The following is a description of a gene set: from publication Kim YS, Kang HS, Herbert R, Beak JY, Collins JB, Grissom SF, Jetten AM (PMID 18227149) Human Gene Set: KIM_GLIS2_TARGETS_UP To obtain insight into the physiological functions of the Krüppel-like zinc finger protein Gli-similar 2 (Glis2), mice deficient in Glis2 expression were generated. Glis2 mutant (Glis2(mut)) mice exhibit significantly shorter life spans than do littermate wild-type (WT) mice due to the development of progressive chronic kidney disease with features resembling nephronophthisis. Glis2(mut) mice develop severe renal atrophy involving increased cell death and basement membrane thickening in the proximal convoluted tubules. This development is accompanied by infiltration of lymphocytic inflammatory cells and interstitial/glomerular fibrosis. The severity of the fibrosis, inflammatory infiltrates, and glomerular and tubular changes progresses with age. Blood urea nitrogen and creatinine increase, and Glis2(mut) mice develop proteinuria and ultimately die prematurely of renal failure. A comparison of the gene expression profiles of kidneys from 25-day-old/60-day-old WT and Glis2(mut) mice by microarray analysis showed increased expressions of many genes involved in immune responses/inflammation and fibrosis/tissue remodeling in kidneys of Glis2(mut) mice, including several cytokines and adhesion and extracellular matrix proteins. Our data demonstrate that a deficiency in Glis2 expression leads to tubular atrophy and progressive fibrosis, similar to nephronophthisis, that ultimately results in renal failure. Our study indicates that Glis2 plays a critical role in the maintenance of normal kidney architecture and functions. species: Mus musculus Partial list of genes up-regulated in the kidney of GLIS2 knockout mice compared to the wild type., and this is the list of marker genes: PSMB9, ISG15, FCGR2A, SYCP1, FCER1G, CCL5, VIM, CXCL10, LAD1, CX3CL1, CCL8, ANGPTL4, TGFBR2, SPARCL1, FBN1, PDGFRL, IGFBP2, TSC22D1, OSMR, S100A6, HLA-DQA2, HLA-DRB1, VCAM1, MMP14, HLA-DMB, EFEMP2, PF4, LSP1, HLA-DRA (NCBI Gene Id 7930), LTB, TGFBI, PDGFRA, SOCS3, IFITM3, PSMB8, BOK, CCL2, SPARC, COL1A1, NID1, CMTM3, CCL23, DPT, CDCA3, ICAM1, HLA-DMA, BBC3, S100A4, CXCL12, CXCL14, POSTN, C3, LTBP2, SPON1, BCL2A1, COL3A1, COL14A1, LUM, CD74, IGLV7-43, TLR2, LILRB1, CCR2, AIF1, TNFSF13B, IGSF10, CCN2, COL1A2, CFH, MATN2, ADAMTS2, OGN, COL4A1, CIDEC, IRF1, SERPINE1, ADAM8, MGP (NCBI Gene Id 4256), COL15A1, COL18A1, HLA-DQB1, DCN, CASP4, PYCARD, MFAP4, MFAP2